The following is a description of a gene set: Any process that modulates the frequency, rate or extent of action potential creation, propagation or termination in a cardiac muscle cell contributing to the regulation of its contraction. studied in species Homo sapiens Human Gene Set: GOBP_REGULATION_OF_CARDIAC_MUSCLE_CELL_ACTION_POTENTIAL_INVOLVED_IN_REGULATION_OF_CONTRACTION, and this is the list of marker genes: HCN4, CAV1, CAMK2D, ATP2A2, CAV3, RANGRF, FGF13, AKAP9